The following is a description of a gene set: Interaction partners of class IIa histone deacetylases (HDAC). In the last decade, the identification of enzymes that regulate acetylation of histones and nonhistone proteins has revealed the key role of dynamic acetylation and deacetylation in various cellular processes. Mammalian histone deacetylases (HDACs), which catalyse the removal of acetyl groups from lysine residues, are grouped into three classes, on the basis of similarity to yeast counterparts. An abundance of experimental evidence has established class IIa HDACs as crucial transcriptional regulators of various developmental and differentiation processes. In the past 5 years, a tremendous effort has been dedicated to characterizing the regulation of these enzymes. In this review, we summarize the latest discoveries in the field and discuss the molecular and structural determinants of class IIa HDACs regulation. Finally, we emphasize that comprehension of the mechanisms underlying class IIa HDAC functions is essential for potential therapeutic applications. Human Gene Set: MARTIN_INTERACT_WITH_HDAC species: Homo sapiens from publication Martin M, Kettmann R, Dequiedt F (PMID 17694086), and this is the list of marker genes: MAPK3, REST, NFKBIA, PHB2, MAPK1, ACTN4, ACTN1, CTBP1, RFXANK, GATA1 (NCBI Gene Id 2623), RUNX3, NRIP1, MARK2, NCOR2, PPP1R12A, ANKRD11, KPNA2, SRF, NR2C1, ETV6, BCL6, BCOR, CAMK1, SIN3A, NCOR1, NKX2-5, PPA1, ATF2, HIF1A (NCBI Gene Id 3091), GATA2, UBE2I, PKD1, FOXP3, CAMTA2, ZBTB16, TP53BP1, CAMK2D, RUNX2, YWHAQ (NCBI Gene Id 10971), KAT5, CBX5